The following is a description of a gene set: Human Gene Set: GOBP_RENAL_WATER_HOMEOSTASIS studied in species Homo sapiens Renal process involved in the maintenance of an internal steady state of water in the body., and this is the list of marker genes: AQP6, ADCY6, AQP2, MLLT6, PRKACB, AQP3, PRKACA, AKAP11, PRKACG, AQP1, ATP6V1B1, MYO5B, CYP4A11, UMOD, HYAL2, INPP5K, CYP4F2, GNAS, AQP4, CYP11B2 (cytochrome P450 family 11 subfamily B member 2), AKR1B1, CYP4F12, WFS1, HAS2